The following is a description of a gene set: Human Gene Set: HP_REDUCED_PROTEIN_S_ACTIVITY Reduced protein S activity An abnormality of coagulation related to a decreased concentration of vitamin K-dependent protein S. Protein S is a cofactor of protein C. species: Homo sapiens, and this is the list of marker genes: PROS1, ALG6, COG8, DPM1, MPI, DPAGT1, GGCX, B4GALT1, ALG12